The following is a description of a gene set: Human Gene Set: MIR2276_5P from publication Chen Y, Wang X (PMID 31504780) species: Homo sapiens Genes predicted to be targets of miRBase v22 microRNA hsa-miR-2276-5p in miRDB v6.0 with MirTarget v4 prediction scores > 80 (high confidence targets)., and this is the list of marker genes: FBXO41, KCND1, ZFHX4, SEMA4G, MSI2, SLC25A16, SZRD1, SLC1A4, PALS1, JRK, MCM9, KATNIP, FAM241B, PGGT1B, TBC1D16, PFDN1, FAM219B, FOXJ3, PNO1, UGGT1, E2F3, POLQ, NMUR1 (NCBI Gene Id 10316), GLIS2, CLIP2, RNF44, DNMT3A, SSTR3, CXXC1, GDF11, ZFAND5, ING4, PLGLB1, KCNQ2, PCNP, TP53INP2, SRSF6, KRT85, PLEKHG4B, TNFRSF13B, TBC1D8B, CCT5, CHST3, ERC2, CP, ZC3H12A (NCBI Gene Id 80149), KBTBD12, RASSF3, B4GALT3, RHBDL3, KLC4, SHCBP1, ZFYVE27, TGIF2, AHCYL1, NEUROD4, ERMN, SP8, PLGLB2, NR4A3, IL5, COBL, MOB3C, FADS1, AAMP, MBNL3, MANBA, EEF2, SH3PXD2A, METTL21A, MARCHF1, NALCN